Given this list of marker genes PBX3, RALBP1, SH3RF1, CC2D2B, WDR26, LRRC8A, NCOA1, FBXL20, KDM6A, VAMP2, CSF1, KCNA3, GNAS, CLLU1-AS1, ATP2A2, DLX4, SPEF1, TAB2, ITGA9, RSRP1, GPRASP2, RAB11FIP2, NR3C1, CTTNBP2NL, ASXL2, SRSF5, AKAP1, EGLN3, STAG2, SPAG9, ATXN7L2, FRAT1, DBNDD2, TOB2, SOCS2, SRGAP3, BICRAL, GMFB, STC1, SLC16A2, EFNA5, ADAMTS6 (ADAM metallopeptidase with thrombospondin type 1 motif 6), SRSF9, FBXO33, ARGLU1, IQSEC2, SEMA4D, NCBP3, GALNT3, UBAP2, TRIT1, MYLK, SLC39A2, MID1IP1, SMG5, OAF, ZNF282, CRYZL1, STAT3, TIMM50, SLC1A1, CLK1, FHOD3, ZDHHC9, ACACA, SPATA1, MSANTD2, ARL8B, RYBP, MNT, BCL7A, PLAGL2, SNX27, NUTF2, RBM12 (RNA binding motif protein 12), CXCL14 (NCBI Gene Id 9547), TRIB2, ARL6IP4, KCNIP2, MIER1, NCOA7, NHSL2, ARL4C (ADP ribosylation factor like GTPase 4C), ACER3, FRAT2, BRD4, RAP1B, CEP192, MMP16, RASGRP2, PHTF2, ATXN1 (ataxin 1), NSD2, ZNRF2, B4GALT1, DBN1, GID4, MANSC1 (MANSC domain containing 1), DLAT, ARHGEF12, DDX3X, EPHB1, OLA1, CCDC47, PIK3C2B, TLK1, DLX3 (NCBI Gene Id 1747), RAB1B, NUMBL, here is a description of the gene set: species: Homo sapiens Human Gene Set: TCCAGAT_MIR5165P Genes having at least one occurence of the motif TCCAGAT in their 3' untranslated region. The motif represents putative target (that is, seed match) of human mature miRNA hsa-miR-516-5p (v7.1 miRBase).